Given this list of marker genes BLM, SMARCA1, RECQL4, RECQL, TP53, ZRANB3, SMARCAL1, RAD54L, here is a description of the gene set: An activity that facilitates the formation of a complementary double-stranded DNA molecule. Human Gene Set: GOMF_DNA_DNA_ANNEALING_ACTIVITY species: Homo sapiens